The following is a description of a gene set: Human Gene Set: REACTOME_SIGNAL_TRANSDUCTION_BY_L1 Signal transduction by L1 species: Homo sapiens, and this is the list of marker genes: L1CAM, RAC1, MAP2K2, VAV2, NRP1, ITGA5, CSNK2A1, EGFR, ITGA9, MAP2K1, PAK1, ITGA2B, ITGB3, NCAM1, MAPK1, MAPK3, ITGB1, CSNK2B, FGFR1, CSNK2A2, ITGAV